The following is a description of a gene set: species: Mus musculus Any process that stops, prevents or reduces the frequency, rate or extent of a signaling receptor activity. Mouse Gene Set: GOBP_NEGATIVE_REGULATION_OF_SIGNALING_RECEPTOR_ACTIVITY, and this is the list of marker genes: Tsg101 (NCBI Gene Id 22088), Tnf, Lilrb4b, Chmp6, Socs4, Ace2, Clec12b, Crhbp, Zgpat, Pparg, Hfe, Zfyve28, Psen2 (NCBI Gene Id 98295), Socs5, Calcr, Cnrip1 (NCBI Gene Id 77064), Cblc, Vps25, Ppara, Errfi1 (NCBI Gene Id 74155), Psen1, Gprc5a, Ramp3, Ptprj, Lilrb4a